The following is a description of a gene set: Human Gene Set: GOMF_OXIDATIVE_RNA_DEMETHYLASE_ACTIVITY studied in species Homo sapiens Catalysis of the removal of a methyl group from one or more nucleosides within a RNA molecule involving the oxidation (i.e. electron loss) of one or more atoms., and this is the list of marker genes: FTO, ALKBH3, ALKBH5 (alkB homolog 5, RNA demethylase), JMJD6, ALKBH1